Given this list of marker genes Kras, Nfib, Igf1, Creb1, Lta4h, Sox9, Ncor2 (nuclear receptor co-repressor 2), Thrb, Thra, Klf2, here is a description of the gene set: species: Mus musculus The process in which a relatively unspecialized cell acquires specialized features of a type I pneumocyte. A type I pneumocyte is a flattened cell with greatly attenuated cytoplasm and a paucity of organelles. Mouse Gene Set: GOBP_TYPE_I_PNEUMOCYTE_DIFFERENTIATION